The following is a description of a gene set: species: Homo sapiens Human Gene Set: GOCC_ESC_E_Z_COMPLEX A multimeric protein complex that can methylate lysine-27 and lysine-9 residues of histone H3. In Drosophila the core subunits of the complex include ESC, E(Z), CAF1 (NURF-55) and SU(Z)12. In mammals the core subunits of the complex include EED, EZH2, SUZ12 and RBBP4., and this is the list of marker genes: PHF1, AEBP2, HDAC2, DNMT3L, JARID2, EZH1, SUZ12, EED, RBBP4, EZH2, SIRT1, RBBP7 (NCBI Gene Id 5931), PHF19, MTF2, TRIM37, EPOP